Given this list of marker genes NSD1, CAVIN1, GPR101, BSCL2, PEX6, ZFX, PHF8, AGPAT2, MEN1, ASNS, SHANK3, FIBP, KDM5C, EED (embryonic ectoderm development), INSR, PACS1, PEX1, AIP, GNPNAT1, KIT (KIT proto-oncogene, receptor tyrosine kinase), NF1, PPARG, RPS6KA3, RNU4ATAC, EZH2, ARCN1, POLR3A, SDHB, SUZ12, FOS, PIGL, SDHC, CAV1, HERC1, POR (cytochrome p450 oxidoreductase), APC2, here is a description of the gene set: studied in species Homo sapiens Human Gene Set: HP_LARGE_HANDS Large hands